The following is a description of a gene set: species: Homo sapiens from publication Chen Y, Wang X (PMID 31504780) Human Gene Set: MIR3200_3P Genes predicted to be targets of miRBase v22 microRNA hsa-miR-3200-3p in miRDB v6.0 with MirTarget v4 prediction scores > 80 (high confidence targets)., and this is the list of marker genes: GRM7, CELF4, COLGALT1 (collagen beta(1-O)galactosyltransferase 1), ANKRD10, AKAP6, REM2, REPS2, ZRANB2, PTGER4, FBN1, RRAGA, AP3S1, AFTPH, KDM2B (NCBI Gene Id 84678), MAP7D3, INSYN2A, DNAJB11, TLR2, USP6NL, TBC1D7, FLT1, CARF (calcium responsive transcription factor), HIPK3, DENND1B, SLC33A1, SHTN1, PURA, FZD3